The following is a description of a gene set: species: Homo sapiens Enables the active transport of a solute across a membrane by a mechanism involving conformational change, where energy for active transport is derived from membrane potential if the solute is charged. Human Gene Set: GOMF_MEMBRANE_POTENTIAL_DRIVEN_UNIPORTER_ACTIVITY, and this is the list of marker genes: SLC17A6, UCP2, SLC17A8, SLC17A9, SLC17A7